Given this list of marker genes VRK1, LAMA2, TPM3, ITGA7, TRPV4, SELENON, HACD1, TPM2, MAP3K20, ACTA1, MYL2, here is a description of the gene set: Human Gene Set: HP_INTERCOSTAL_MUSCLE_WEAKNESS species: Homo sapiens Intercostal muscle weakness Lack of strength of the intercostal muscles, i.e., of the muscle groups running along the ribs that create and move the chest wall.